The following is a description of a gene set: species: Homo sapiens Genes predicted to be targets of miRBase v22 microRNA hsa-miR-26a-5p in miRDB v6.0 with MirTarget v4 prediction scores > 80 (high confidence targets). Human Gene Set: MIR26A_5P from publication Chen Y, Wang X (PMID 31504780), and this is the list of marker genes: MAP3K7, TMCC1, UCK2, USP3, SLC35E4, ESR1, COMMD8, SLC16A6, NEK1, SLC9A2, GPR52, SRP19, HOXD13, RTF1, UBE2H, FANCF, HTR1B, SELP, CTNND2, MAP7, MIER3, WNK1, ADAMTS19, PLEKHH1, UBE4B, BRWD1 (NCBI Gene Id 54146), RLF, PRKCQ, SNN, PFDN4, TANC2, NUS1, CARMIL1 (NCBI Gene Id 55604), GPALPP1, ZNF516 (NCBI Gene Id 9658), PARPBP, PEX13, BAG4 (BAG cochaperone 4), SRGAP1, RPGR, MLANA, CACNB2, BEND4, CDK2AP1, ELAVL2, ADAM17, ANKRD28, LOXL2, ZDHHC18, NFE2L3, EYA3, ATAD1, ABHD5, MAEA, RYK, CAMSAP2, PAN3, ABL2, FAM98A, MTX2, CHSY1, BFAR, RCN2, PPP4R1 (protein phosphatase 4 regulatory subunit 1), YTHDF3, STK39, CCDC82 (coiled-coil domain containing 82), MRAS, KLF4, CPPED1, APPL2, ADRA1A (adrenoceptor alpha 1A, NCBI Gene Id 148), PTPRD, FAM8A1, ETNK1, KLHL42, SLC33A1, BCR, DCDC2, PELI2, MAB21L1, FA2H, CHAC1, KPNA2, EZH2, NCEH1, ARK2N, ADAM19, COL1A2, NIPAL2, AMOT, TENT2, CELSR1, LEF1, BBS7, TNNT1, CCDC6, CNTNAP3B, SLC24A4, PGRMC2, OSBPL2, MXI1, SLC25A20, MCL1, SLC2A13, RHOQ, LMLN, BAZ2B, OTUD4, HEPHL1, ERC2, TAF9B, PTEN (NCBI Gene Id 8037), B4GALT4, TMEM135, SLC45A4, SLC30A7, REST, BARD1, CTSV (cathepsin V), MYH10, SLC1A1, ZNF608, IL18R1, KCNQ4, NABP1, FGF18, GRHL3, CDH20, JAG1, ULK1, SUZ12, KPNA6, ANKS1A, MTDH, RCOR1 (NCBI Gene Id 23186), MAN2A1, CARF, STRADB, PPP3R1, GNA13, CDK8, TOP1, STYX, YAF2, USP53, ACBD5 (acyl-CoA binding domain containing 5), HMGA2, SENP5, RAB21, PAWR, IQCJ, E2F7, PSD3, SKP2, CREB1, DMXL1, ADM, HERC2, ZDHHC6 (NCBI Gene Id 64429), RALYL, FHIP1A, STXBP5, SPDYE5, ICE1, TOB1, BBX, PALM3, SULF1, CCND2, TMC7, SLC25A16, SRCAP, RAP2C, RPS6KA6 (ribosomal protein S6 kinase A6), ARB2A, MKNK2, ALS2, RNF141, PDHX, SH3RF1, TRIB2, OSBPL11, SLC19A2, MCUR1, SLC36A4, ZIC5 (Zic family member 5), RCBTB1, RASSF3, ARFGEF1, SOCS7, HGF, BLOC1S2, NAA15, UGT8, B3GNT5, LARP1, GABRB2 (NCBI Gene Id 2561), PFKFB3, LIN28B, MAP2, RFK, TMEM260 (transmembrane protein 260), DENND1B, CACNA1C, TNRC6C, FAM136A, MATR3, TGIF2-RAB5IF, CNTNAP3, DUSP5, ATXN7, SNX20, SMAD1, PALS2, SEPTIN10, SLC22A23, UBA5, PHTF2, UBE2G1, GPSM1, MICAL3, CTXN3 (cortexin 3), PPP3CB, NAP1L5 (NCBI Gene Id 266812), EIF4G2, PHF20L1, RCC1L, APCDD1, MAT2A, SLC7A11, ARPP19, ZNF410, TET1, NATD1, ATF2, ITGB8, MFSD14A, CPED1, DDX17, ZSWIM6, LSM12, SEMA6D, FBXO28 (F-box protein 28), TRIM65, NIPA1, ADAMTS6, JARID2, CREBRF, RBM24 (NCBI Gene Id 221662), EIF5, ST6GAL2, RNF6, NUDT11, EP300, SLC38A2, THAP2, TET2, BID, FAM199X, PHAF1, RHOU, HOXA9, DLG5, TBC1D4, COL10A1, CCDC28A, FBXO11, DMRT3, CCNJ, TNRC6B (NCBI Gene Id 23112), ART3, CHORDC1 (NCBI Gene Id 26973), TMEM68, PFKFB2 (6-phosphofructo-2-kinase/fructose-2,6-biphosphatase 2), RHD, TET3, ZBTB18, PIK3R3, POLR3G, PAG1, SFT2D3, NID1, GSK3B, ATM, RCN1, FBXL19, TMEM106B, ADAM9, SH3PXD2A, CELF2, TRANK1, TBC1D30, NAGPA, MAPK6, ARL5B, RB1, HSPA8, ZFHX4, RSPRY1, NLK, LNX2, TTPAL, PCDH18, FPGT, THUMPD3, WNK3, SLC5A1, FRMD4B, REEP3, BOD1, NAMPT, VGLL4, UBE2E2, PHF6, GMNC, NUP50, RBM20 (NCBI Gene Id 282996), C2CD5, TBC1D15, EPC1, GMDS, ZFC3H1, ASPN, SRSF6, KBTBD8, UBE2J1, ABCC4, MARK1, MTM1, KIAA2013, HOXA5, TNRC6A, ZNF598, SAMD8, CTTNBP2NL, VDAC1, EIF2S1, PTGS2, FRAT2, CAMSAP1, NAB1, PLOD2, MTFMT, CRADD, ANKRD63, CPD, MMP16, FGD1, AKAP7, SHANK2, TTPA, TMEM265, CPSF2, PIM1, PRR5L, OVOL2 (ovo like zinc finger 2), PITPNC1, HMGA1, PLEKHG1, RDH14, PHF21A, SV2C, ATAD2B, TM2D3, GNPNAT1, TMEM184B, BAK1, MTTP, CILP, TMEM86A, TNPO1, EP400, BHLHE40, CTH, RAB5IF, KLHL18, GABRA4 (NCBI Gene Id 2557), ULK2, SLC4A4, ATPAF1, MDN1, VANGL2, SFXN1, HOXC4, CDH4, ANKS1B, PLCB1, PPP1R15B, RGS4, INHBB, SYT10, ACADM, ITGA6, CREBBP, CNOT4, SSX2IP, CXADR, USP25, ZDHHC20, TRPC3, GOLGA3, YPEL1, DAPK1, CEMIP2, PHF14, ATP11C, CD200, PHF3, ARMCX2, FLVCR1, PLP1, PCNX1, MSMO1, CHD1, PPP1R3D, SLC2A14, ZNF235, KCNJ2, USP9X, TTC13, CEP350, ERLIN1, PRKCD, RESF1, ZNF469, TWF1, NACC2 (NCBI Gene Id 138151), GMFB, ITGA5, EPB41L3, ZNF664, PECAM1, PHLDB2, G3BP2, ALDH5A1, EPC2, HAS3, SLC25A36, ZNF462, USP37, SBNO1, SACS, COL19A1, ACSL3, TFAP2A, PMAIP1, ARL6IP6, TAOK1, CLASP2, NT5C1B-RDH14, ATP1A2, CREBZF, TAF2, SCAMP1, PAK2, PGM2, DGKH, BTG1, NHS, STRBP, CSRNP2, MIER1, CHFR, POLH, SERBP1, ZCCHC24, CIPC, UBR3, CDC6, LTBP1, UBN2, TMEM248, USP15, ARHGAP21, SSH2, DOCK4, PARP14, G2E3, ADAM23, LSM11, CASZ1 (castor zinc finger 1), PCDH9, LRRC2, DNA2, EAF1, CDK6, NCOA4, ACVR1C, SFPQ, TP53INP1, BLTP3A